The following is a description of a gene set: A process in which a host organism modulates the frequency, rate or extent of any of a process being mediated by a virus with which it is infected. Mouse Gene Set: GOBP_MODULATION_BY_HOST_OF_VIRAL_PROCESS studied in species Mus musculus, and this is the list of marker genes: Fasn, Fmr1, Nucks1, Zc3h12a, Eea1, Rock2, Ccl8, Stom, Prkn, Tmem41b, Zfyve1, Smc6, Phb1, Vapb, Vapa, Pcx, Ptx3, Paip1, Ythdc2 (YTH domain containing 2), Ccnk, Pik3c3, Tbc1d20, Cfl1, Zdhhc9, Ppib (NCBI Gene Id 19035), Pik3c2g, Apoe, Ddx56, Rab5a, Csf1r, Zdhhc20, Eif2ak4, Apcs (amyloid P component, serum), Smc5, Pi4ka, Hspa8, Cav2, Zdhhc8, Rab29, Cdc42, Ltf, Fbxl2, Ifng, Eef1a1, Igf2r